The following is a description of a gene set: species: Mus musculus Mouse Gene Set: chr1H6, and this is the list of marker genes: Gm2367, Slc30a1, Smyd2, Kctd3, Utp25, Pdcd5-ps, Gm8407, Irf6, Gm30725, Pacc1, Gm10516, Gm32460, Ints7, Gm26670, Cd46, Cenpf, Vash2, Gm38022, Ush2a (usherin), Ppp2r5a, Gm26574, Prox1, 1700065J18Rik, Traf3ip3, Kcnh1, Gm25269, Atf3, Syt14, 2900042K21Rik, Gm31406, Gm32200 (predicted gene, 32200), 9630010A21Rik, Flvcr1, Gm29678, Nsl1, Gm25095, 2900035J10Rik, Rd3 (NCBI Gene Id 74023), Gm21362, Mir29b-2, Batf3, Ptpn14, G0s2, Gm20203 (predicted gene, 20203), Rps6kc1, Gm15867, A330023F24Rik, Plxna2, 4930570N18Rik (RIKEN cDNA 4930570N18 gene), Dtl, Rcor3, 1700034H15Rik, A230020J21Rik, Gm18698, Lpgat1, Tatdn3, Sertad4, Gm30280, A730013G03Rik, Spata45, Cr1l, Lamb3, Cd34, Hhat, Prox1os, Gm2272, Traf5, Gstp-ps, Mir205hg, Kcnk2, Mir205, Mir3962, Nenf, Gm31373, Nek2, A430027H14Rik, 9430037O13Rik, Gm30932 (NCBI Gene Id 102632999), Mir29c (microRNA 29c), Angel2, 4930503O07Rik, Camk1g, Gm26203, Gm16897, Garin4, A130010J15Rik, Gm19777, Hsd11b1, D730003I15Rik, Mir3473c, Cr2